The following is a description of a gene set: The immune responses generated by YF-17D by profiling genes in PBMCs from 2 donors cultured with YF-17D vaccine were accessed after 3 and 12 hours. Genes up-regulated in comparison of unstimulated peripheral blood mononuclear cells (PBMC) versus PBMC stimulated with YF17D vaccine. studied in species Homo sapiens Human Gene Set: GSE13484_UNSTIM_VS_YF17D_VACCINE_STIM_PBMC_UP from publication Querec TD, Akondy RS, Lee EK, Cao W, Nakaya HI, Teuwen D, Pirani A, Gernert K, Deng J, Marzolf B, Kennedy K, Wu H, Bennouna S, Oluoch H, Miller J, Vencio RZ, Mulligan M, Aderem A, Ahmed R, Pulendran B (PMID 19029902), and this is the list of marker genes: PAGR1, DAP3, PITPNM1, PREB, KDM3A, MOAP1, AP1S2, RPL22, SHLD2, RXRA (NCBI Gene Id 6256), ESYT1, ARMCX5, ELAVL1, ARF5, MTMR14, GLRX5, SARS1, PBXIP1, NKRF (NCBI Gene Id 55922), WDR37, AP3S1 (NCBI Gene Id 89412), EIF4EBP1, UBE4A, TRBC1, ZNF354A, RNF113A, ATP5PB, IDH3G, USP1, CEBPA, NDUFB1, GDI2, ABHD2, NUP50, ELP1, ASAH1, TXN2, ZDHHC7 (NCBI Gene Id 55625), ABITRAM (actin binding transcription modulator), LCP1, HLTF, FBXO9, SH3TC1, REV3L, SPAST, SEC24B, TWF2, TRIM8 (tripartite motif containing 8), HECA, BRPF1, C1orf35, CACYBP, DOK2, GAMT, DSTN, DNAJB1, AQP3, KCTD12, API5, FOXJ2, RPN2, ZDHHC3, PAK2 (NCBI Gene Id 9106), SRSF8, PRPF31, PPIP5K2, DDX42, ADCY7, SF3B1, RPL21, HADH, XRCC5, TMF1, RASSF2, SORL1, SEPTIN2, MAP3K3, TSN, AGO1, XPA, THOC6, PRPF8, SKIC8, PTP4A2, CSNK1G3, SPCS3, TUBGCP2, ERCC5, MAEA, RGP1, RPA1 (NCBI Gene Id 6117), ZFAND3, ACP1, TTC3, SMIM10L1, NIPSNAP2, FBXW2, GRAMD4, HNRNPH3, WBP1L (NCBI Gene Id 54909), CPSF6, CLINT1, LSM14B, EDC4, AMZ2, MRPS15, HACD2, PARK7, RNF130, KANSL2, KAT6B, MYCBP, NFRKB, KLHDC2 (NCBI Gene Id 23588), MBTD1, ZNF34, AQR, UQCRC1, ANKZF1, CALHM2, SS18L1, KIDINS220, ZBED5, FAM168B, PIH1D1, ZC3H14, DDX41, LTN1, SUPT16H, GAPVD1, PEPD, SUN1, COPS3, SSR2, ATPAF2, EIF2B4, EXOC3, NACC2, NR2C1, SSR1, RREB1, METAP1, CUTC, XPO7, PLXNB2, EIF2B1, PJA2, FRAT1, MAN2B1, MNT, LBR, CARHSP1, POLR2B, TUT4, RGS19, XPOT, PFKFB4, DKC1, SLC25A46 (NCBI Gene Id 91137), IFFO1, TMEM11, RASA1 (NCBI Gene Id 5921), TOP2B, SASH3, PPP6C, ANP32B, WDR83OS, PCM1, ST13, ARPC1B, RMND5A, PARL, ACTR2, PUM2, PHF2, PFDN5, TBC1D8, CTBP2, CCR2, MYO9B, ATP5F1A (NCBI Gene Id 502), QRICH1, SLC35A1, DCP2, PBX3, MTSS1, RPL35A, PACSIN2, SHCBP1, SEPTIN7, SEC11A, CHD9, LDLRAP1, MFNG, NARS1, USP22, MAP3K7, SRSF1, CREBZF, NDUFB8